Given this list of marker genes MIR141, CXCL12, MIR222, MIR125A, MIR221, MIR31, MIRLET7E, KLF4, CCL28, CCL25, MIRLET7G, MIR146A, CCL21, here is a description of the gene set: Any process that stops, prevents or reduces the frequency, rate or extent of leukocyte adhesion to vascular endothelial cell. Human Gene Set: GOBP_NEGATIVE_REGULATION_OF_LEUKOCYTE_ADHESION_TO_VASCULAR_ENDOTHELIAL_CELL species: Homo sapiens